Given this list of marker genes H6pd (hexose-6-phosphate dehydrogenase (glucose 1-dehydrogenase)), Gpi1, Shpk, Mtor, Prps2, Prps1, Hk2, Acacb, Nfe2l1, Aldob, Rpia, Hk3, G6pdx, Trp53, Taldo1, Pgls, Tigar, G6pc3, G6pc1, G6pc2, Rpe, Pgd, Mlst8, Hkdc1, Gck, Tkt, Hk1, Rptor, G6pd2, Hsd11b1, Rbks, here is a description of the gene set: The chemical reactions and pathways involving glucose 6-phosphate, a monophosphorylated derivative of glucose with the phosphate group attached to C-6. Mouse Gene Set: GOBP_GLUCOSE_6_PHOSPHATE_METABOLIC_PROCESS studied in species Mus musculus